Given this list of marker genes ELK1, SMC1A, SMC3, NIPBL (NCBI Gene Id 25836), GLI3, here is a description of the gene set: studied in species Homo sapiens Binding to a mediator complex. The mediator complex is a protein complex that interacts with the carboxy-terminal domain of the largest subunit of RNA polymerase II and plays an active role in transducing the signal from a transcription factor to the transcriptional machinery. The Saccharomyces complex contains several identifiable subcomplexes: a head domain comprising Srb2, -4, and -5, Med6, -8, and -11, and Rox3 proteins; a middle domain comprising Med1, -4, and -7, Nut1 and -2, Cse2, Rgr1, Soh1, and Srb7 proteins; a tail consisting of Gal11p, Med2p, Pgd1p, and Sin4p; and a regulatory subcomplex comprising Ssn2, -3, and -8, and Srb8 proteins. Metazoan mediator complexes have similar modular structures and include homologs of yeast Srb and Med proteins. Human Gene Set: GOMF_MEDIATOR_COMPLEX_BINDING